The following is a description of a gene set: Human Gene Set: HP_FUNCTIONAL_INTESTINAL_OBSTRUCTION species: Homo sapiens Functional intestinal obstruction, and this is the list of marker genes: SMAD4, ERBB3, KRAS (KRAS proto-oncogene, GTPase), PALB2, CDKN2A, BRCA2, TP53, BRCA1, PALLD, RABL3